Given this list of marker genes PGAP1, CTNNB1, ITPR1, MDH2, SON, HIVEP2, CELF2, MRPS25, RBL2, here is a description of the gene set: Human Gene Set: HP_DELAYED_ABILITY_TO_CRAWL Delayed ability to crawl studied in species Homo sapiens A failure to achieve the ability to crawl at an appropriate developmental stage. Normal infant motor development is marked by a series of postural milestones including learning to crawl on hands and knees between the ages of 6 and 10 months.